Given this list of marker genes Oxt, Svs3a, Tacr1, Slc6a4, Klk14, Oprm1, P2rx1 (NCBI Gene Id 18568), Oxtr, Serpine2, Acvr2a, Avpr1a, Ddo, Tgm4, here is a description of the gene set: Mouse Gene Set: GOBP_INSEMINATION species: Mus musculus The introduction of semen or sperm into the genital tract of a female.